The following is a description of a gene set: Any process that activates or increases the frequency, rate or extent of keratinocyte differentiation. Human Gene Set: GOBP_POSITIVE_REGULATION_OF_KERATINOCYTE_DIFFERENTIATION species: Homo sapiens, and this is the list of marker genes: MED1, ALOX15B (arachidonate 15-lipoxygenase type B), NUMA1 (NCBI Gene Id 4926), FOXC1, VDR, NOTCH1, PLAAT4, TRIM16, NME2, ZBED2, NCOA3, PRKCH, PKP1, MIR125B1, CYP27B1, IL20 (NCBI Gene Id 50604), SPRR5, MACROH2A1, OVOL2, ETV4, MACROH2A2